Given this list of marker genes Mmp28, Stap1, Cmklr1, Slamf8, Ptprj, Cx3cl1 (C-X3-C motif chemokine ligand 1), Trem1, Mst1, Mtus1, Rarres2 (retinoic acid receptor responder (tazarotene induced) 2), Mdk, Akirin1, C5ar1, Ccl2, Il34 (interleukin 34), Trpv4, Mapk3, Csf1r, Mapk1, Cxcl17, Ptk2b, Ccl5, Mif, Thbs1, Hc, Mstn, Csf1 (colony stimulating factor 1 (macrophage)), Ptk2, Cyp19a1, Ccr7, C3ar1, Ccl21a, Tnfsf18, Slamf1, here is a description of the gene set: Mouse Gene Set: GOBP_REGULATION_OF_MACROPHAGE_CHEMOTAXIS Any process that modulates the rate, frequency or extent of macrophage chemotaxis. Macrophage chemotaxis is the movement of a macrophage in response to an external stimulus. species: Mus musculus